Given this list of marker genes MAPK7, PKN2, PRKACB, KLF2, KLF4, XBP1, NFE2L2, PDPK1, MIR126, SREBF2, PRKACA (NCBI Gene Id 5566), GNAS, CAPN2, AKT1 (AKT serine/threonine kinase 1), ASS1, PRKACG (protein kinase cAMP-activated catalytic subunit gamma), MTOR, MAP2K5, here is a description of the gene set: Human Gene Set: GOBP_CELLULAR_RESPONSE_TO_LAMINAR_FLUID_SHEAR_STRESS species: Homo sapiens Any process that results in a change in state or activity of a cell (in terms of movement, secretion, enzyme production, gene expression, etc.) as a result of a laminar fluid shear stress stimulus. Laminar fluid flow is the force acting on an object in a system where the fluid is moving across a solid surface in parallel layers.